The following is a description of a gene set: SARS-CoV-1 mRNA is translated according to the ribosomal scanning model. Virus mRNA is capped and polyadenylated, with regions of nontranslated sequences on both the 5' and 3' ends. Structural proteins are encoded after the polymerase/replicase genes by mRNAs 2 (Spike protein), 3, 4 (Envelope protein), 5 (Membrane protein), and 9. mRNA 3 and 9 are bicistronic, the proteins 3a and 9a (Nucleocapsid protein) having functions in virus assembly and structure. Translation happens in the ER with the exception of 9a which is translated by cytosolic free ribosomes. Reactome Pathway: Translation of Structural Proteins_9683701 species: Homo sapiens part of: SARS-CoV-1 Infection, and this is the list of marker genes: S, UBA52, ST3GAL4, SUMO1, ST3GAL3, UBC, MOGS, GALNT1, UBE2I, ST6GALNAC4, GANAB, MGAT1, GSK3A, PARP9, N, ST6GAL1, ST6GALNAC3, ST6GALNAC2, PARP10, PARP14, 3a, SARS coronavirus, complete genome, UBB, PARP16, ST3GAL2, GSK3B, CANX, PARP6, PRKCSH, PARP8, PARP4, RPS27A, E, ST3GAL1, M